The following is a description of a gene set: from publication Elo LL, Järvenpää H, Tuomela S, Raghav S, Ahlfors H, Laurila K, Gupta B, Lund RJ, Tahvanainen J, Hawkins RD, Oresic M, Lähdesmäki H, Rasool O, Rao KV, Aittokallio T, Lahesmaa R (PMID 20620947) Human Gene Set: GSE17974_0H_VS_6H_IN_VITRO_ACT_CD4_TCELL_UP The aim of this dataset was to study in detail the transcription kinetics initiated by cytokine IL-4 in early differentiation of Th2 cells. Genes up-regulated in comparison of untreated CD4 T cells at 0 h versus the untreated cells at 6 h. species: Homo sapiens, and this is the list of marker genes: PTK2B, SLC9A9, PPP3CC, PSTK, BIN1, IL11RA, RAPGEF2, CPEB2, AGPAT4, AGTPBP1, ZNF592, MXD1, GTF2IRD2, MLLT11, MYLIP, UBE2Q2P13, ITGA4, UCP2, ROGDI, AK5, ZNF8, ING2, ARIH2OS, VPS9D1, DNAJC4, UGT2B17, SKIL, MAN2B2, RNF10, TSPYL4, ARRB2, TCEA3, RFX3, LINC00173, TJP2, FAM13A-AS1, ZBTB20, HSD17B11, MEF2D, CCDC69, ZBTB4, TSC22D1, ITCH, SYTL1, TPP1, VIPR1, ACAP1, SOX4, SUSD4, TENM1, MT2A, FNIP1, SNN, ARRDC3, ZDHHC11 (zinc finger DHHC-type containing 11), NOL4L, DHRS7, DOK2, PTPRT, ZNF101, C9orf72, KCTD3, SYNM, ENSG00000240207, ARHGEF11, PARP8, RAP1GAP2, SRD5A1, EFHC2, FAM24B, RGS1, KAT6B, ST3GAL5, GKAP1, TSC22D3, ZNF34, EPHX2, MAFF, MDS2 (myelodysplastic syndrome 2 translocation associated), ERP27, MYO1F, BIN2, KCNA3, PIK3R5, PDCD4-AS1, MORC2-AS1, ZFAND1 (zinc finger AN1-type containing 1), DIAPH2, EPHA4, PRDM5 (NCBI Gene Id 11107), DDIT4, LYRM9, SMIM10L1, ZBED10P, GPATCH2, FOSL2, LINC02035, TOB1, FAM111A, G0S2, SPON2, LINC00938, NDRG1, RNF125 (ring finger protein 125), SUCLG2 (NCBI Gene Id 8801), CHD9, PARP3, ZNF831, HKDC1, NEU4, TP53INP2, LIME1, SOCS3, PRKCA, MYO1G, SAMHD1, IL10RA, PTP4A1, PCSK5, PRLR, CORO1B, ENSG00000288011, ENSG00000280119, PTPRM, IRS2, HYKK, UTRN, ABHD3, ENPP2, DPEP2, ITGAM, CLIC6, AREG, KLF7, RBM33, ZNF256, GABBR1, KLF4, LPP, TTC28, CITED2, RETREG1, PELI2, ASB16-AS1, TBC1D5, KIFC2, FHIT, NMT2, TRAM2, MCUB, AKTIP, NET1, IRF2BPL, CD4, PTGS2, PDE4D (NCBI Gene Id 654081), FAM8A1, IRF2BP2, MBNL2, ADM, DCTN3, SMYD3, TSPAN32, TPM2, PDCD6P1, GPRASP2, ENC1, CMC4, SLC2A3, ASH1L-AS1, PSTPIP1, C16orf54, GJB6, FAM200B, KLF11, FBXO33, TTC32, PDE9A, HEBP2, ITPRIP, SRGAP3 (SLIT-ROBO Rho GTPase activating protein 3), DUSP1, JUN, SIAE (NCBI Gene Id 95985), UBASH3B, H1-10, GSE1, GADD45A, BAG3, MT1F, DYNLT2B, GSTM1